Given this list of marker genes HERPUD1, FAM8A1, OS9, SEL1L, SYVN1, MARCHF6, UBE2J1, here is a description of the gene set: A ubiquitin ligase complex found in the ER. Human Gene Set: GOCC_ER_UBIQUITIN_LIGASE_COMPLEX species: Homo sapiens